Given this list of marker genes GRB2, PTPN11, FLT3LG, GAB2, STAT5A, FLT3 (NCBI Gene Id 2322), STAT5B, here is a description of the gene set: studied in species Homo sapiens Signal transducer and activator of transcription (STAT) constitutes a family of universal transcription factors. STAT5 refers to two highly related proteins, STAT5A and STAT5B, with critical function in cell survival and proliferation. Several upstream signals including cytokines and growth factors can trigger STAT5 activation. part of: FLT3 Signaling Reactome Pathway: STAT5 Activation